Given this list of marker genes KLF8, DHX57, TSPEAR, ARK2C, RAB8B, NIPAL4, CERT1, XRN1, SENP2, TAF9B, ZNF275, FIGN, C19orf47, STIMATE, SLC25A27, STARD9, RALB, ZBP1, SOCS4, PBX3, GALNT1, TMPPE, COL3A1, FNIP1, RASGRP1, GXYLT1, PTAFR, MYCN, CADM2, OSMR, ZBTB8B, PRSS22, UGCG, CCNJ, CCND2, AEN, ERO1A, SCN11A, MTDH, MRS2 (magnesium transporter MRS2), KLHDC8B, STARD13 (StAR related lipid transfer domain containing 13), PCGF3, ACTA1, DIP2A, CDC25A, VCF1, COL4A2, MBD2, PDE12, ARHGAP28, POLL (NCBI Gene Id 27343), STRBP, USP44, WNT9B, ZFYVE26, ADRB3, CLDN16, KCNJ11, XKR8, CEP120, NRAS, OPA3, SMC1A, RAB11FIP4, LBR, ANKRA2, KLHL31, E2F5, ZNF322, SLC20A1, TRIM71, CPA4, COL27A1, LRIG2, IGDCC4, SNX30, GYG2, NGF, GAS7, DNAJA2, TRIM67, STK40, ENTPD7, PCDH19, PLEKHA8, UHRF2, ABL2, IGDCC3, ZNF583, SLF2, MIB1, SENP5, TET3, GJC1, CDKN1A, SALL3, RGS16, ATL2, SUB1, ADRB2, CERCAM, CLP1 (cleavage factor polyribonucleotide kinase subunit 1), C15orf39, FIGNL2, BEGAIN, GPATCH2, POLR3D (NCBI Gene Id 661), IGF2BP1, BIN3 (NCBI Gene Id 55909), VIRMA, CLCN5, PEX11B, PIK3IP1, GATM, HDX, SLC2A12, NHLRC3, GPR26, RIMOC1, PLXND1, THRSP, BZW1, HSPA14, NEK3, LIPT2 (NCBI Gene Id 650826), PDPR, LEPROTL1, ARMT1, HECTD2, ONECUT2, TGFBR1 (NCBI Gene Id 7046), HOOK1, PRTG, SLC5A9, LIN28B, PARPBP, ZNF512B, AP1S1, DLST, CBX5, KCTD21, NR6A1, CEMIP2, TMPRSS2, KLF9, ZNF784, NME4, IQCB1, HAND1, OSBPL3, SKIL, GPCPD1, INSR, E2F2, YOD1, MED8, POGZ, LIMD2, NYNRIN, AKAP6, PEG10, CDC34, FAM135A, SALL4, KCNC2, C14orf28, DLC1, KDM3A, FZD4, MARS2, TTLL4, ARL5A, TMEM167A, PXT1, RUFY3, ARHGEF38, ZNF710, TGFBR3, ZBTB5, XK, MDM4, GAN, PAPPA, SLC10A7, ERCC6, CPEB2, DDX19A, DVL3, HIP1, KCTD17, TBKBP1 (TBK1 binding protein 1), HIC2, MASP1, CARNMT1, NAP1L1, SLC38A9 (solute carrier family 38 member 9), HIF1AN, GABBR2 (NCBI Gene Id 9568), SEMA4C, FNIP2, GTF2I, COIL, AGAP1, GDF6, PXDN, GALNT2, PLEKHO1, EFHD2, PLEKHG6, SNX16, FRAS1, SIGLEC14, CHD4, TNFSF9, ASAP1, IRS2, PLXNC1, SRGAP1, IGF2BP2, PTPRD, NME6, DTX4, IL13, COL4A1, NPHP3, IGF2BP3, BACH1, ENTREP2, ACVR1C, FZD3, HOXD1, ABCB9, CPEB1, EEA1 (NCBI Gene Id 8411), PIGA, B3GNT7, CEP135, PLPP5, TSEN34, SDK1, ZNF280B, AMOT, LIPH, DNAJC1, ZNF644, EIF4G2, ABCC5, SCN4B, AGO4, RBFOX2, MAPK8, COL4A6, PLAGL2, CCL7, PLA2G3, FNDC3A, IGF1R, STX3, CNOT6L, BEND4, RGS6, USP24, ELP1, GNPTAB, ACER2, PABIR1, B4GAT1, ADAMTS8, ERCC4, PBX2, FBXL12, FRMD4B, CASP3, ZNF516, EDEM3, E2F6, ARID3B, AHCTF1, SIGLEC5, IMPG2, SMARCAD1, RICTOR, SLC5A6, FAXC, RFX6, PBX1, SLC16A9, PPP1R15B, COL1A2, DDX19B, HOXA1, TSC1, MAP4K3, GNG5, PRRX1, FGF11, DTX2, RSPO2, ADAMTS15, GFM2, HMGA2, UTRN, DUSP1, ATP8B4, LIN28A, ATP2A2, USP38, AMT, SFMBT1, RNF20, TMEM121B, ZSWIM5, PLPP6, CD59, SLC35D2, APBB3, THOC2, MTRES1, ABT1, FASLG, HAS2, HDLBP, RDX, DMD, CD164 (NCBI Gene Id 8763), GALC, DPP6, MMS22L, DCAF15, LINGO1, LRIG3, EEF2K, TMEM65, LAMP2, NKAPD1 (NKAP domain containing 1), LPGAT1, MAPK6, C8orf58, SPRYD4, SMIM3, PPP1R16B, MAP3K9, TMOD2, ELF4, XYLT1, ITGB3, CLDN12, SLC31A2, DNA2, PALD1, CRTAM, PGRMC1, GCNT4, EDN1, DDI2, here is a description of the gene set: from publication Chen Y, Wang X (PMID 31504780) studied in species Homo sapiens Human Gene Set: MIR4458 Genes predicted to be targets of miRBase v22 microRNA hsa-miR-4458 in miRDB v6.0 with MirTarget v4 prediction scores > 80 (high confidence targets).